Given this list of marker genes LRP4, TENT5A, COPB2, ANO5 (anoctamin 5, NCBI Gene Id 203859), GJA1 (gap junction protein alpha 1), WDR62, COL1A1, FLNA, KIF14, VDR, SFRP4, LIFR, SLCO2A1, WARS1, MCM7, MCPH1 (microcephalin 1), MAN2B1, PHC1, SLC34A3, TMEM38B, ANKLE2, GLE1, PRKG2, CEP63, SLC4A2, PIGA, PEX19, PTH1R, AGA, KIF1A, CDK5RAP2, MMP2, NCAPD3, SERPINH1, TRAPPC10, PYCR2, CENPE, CEP135, SMS, CDK6, METTL5, ADAMTS10, TRAPPC14, TBCE, XYLT2, TCIRG1, NSDHL, MFSD2A, SH3PXD2B, PLEKHM1 (pleckstrin homology and RUN domain containing M1), DMP1, AKT1, CCDC134, TGFB1, WNK1, STIL, ENPP1, FAM111A, CLCN5, KNL1, FBN1 (NCBI Gene Id 7470), HPGD, ASPM, CEP152, AXIN1 (NCBI Gene Id 8312), LEMD3 (NCBI Gene Id 23592), TBXAS1, TAF13, ANKH (NCBI Gene Id 7995), FARSB, NF1, TRPV4, PTDSS1 (phosphatidylserine synthase 1), NUP37, SCN9A, SASS6, CYP2R1, SETBP1, CLCN7, CIT, LRP5, CYP27B1, GLB1, TRIM37, SOST, SARS1, TNFRSF11A, RETREG1, TMEM53, here is a description of the gene set: Human Gene Set: HP_ABNORMAL_CORTICAL_BONE_MORPHOLOGY Abnormal cortical bone morphology studied in species Homo sapiens An abnormality of compact bone (also known as cortical bone), which forms the dense surface of bones.